The following is a description of a gene set: The process in which the nucleoprotein complex (composed of the broken single-strand DNA and the recombinase) searches and identifies a region of homology in intact duplex DNA. The broken single-strand DNA displaces the like strand and forms Watson-Crick base pairs with its complement, forming a duplex in which each strand is from one of the two recombining DNA molecules. species: Homo sapiens Human Gene Set: GOBP_DNA_STRAND_INVASION, and this is the list of marker genes: PSMC3IP, RAD51, XRCC2, WRN, RAD51D, DMC1